The following is a description of a gene set: studied in species Homo sapiens Pathway Definition from KEGG: LANA -| GSK3B -| CTNNB1 -> TCF/LEF => CCND1 KSHV LANA to Wnt signaling pathway. Pathway ID: N00175. Pathway type: Pathogen. Pathway class: nt06505 WNT signaling. Human Gene Set: KEGG_MEDICUS_PATHOGEN_KSHV_LANA_TO_WNT_SIGNALING_PATHWAY, and this is the list of marker genes: TCF7, GSK3B, TCF7L2, CCND1, CTNNB1, LEF1, TCF7L1